Given this list of marker genes XYLT2, BICD2, TCIRG1 (T cell immune regulator 1, ATPase H+ transporting V0 subunit a3), LEMD2, TNFRSF11A, here is a description of the gene set: Femur fracture A break or crush injury of the thigh bone (femur). studied in species Homo sapiens Human Gene Set: HP_FEMUR_FRACTURE